Given this list of marker genes Bdnf, Ntf5, here is a description of the gene set: electronically inferred by orthology from the curated human pathway species: Mus musculus This event has been computationally inferred from an event that has been demonstrated in another species.<p>The inference is based on the homology mapping from PANTHER. Briefly, reactions for which all involved PhysicalEntities (in input, output and catalyst) have a mapped orthologue/paralogue (for complexes at least 75% of components must have a mapping) are inferred to the other species. part of: Signaling by NTRK2 (TRKB) Reactome Pathway: Activated NTRK2 signals through PLCG1